Given this list of marker genes CARD10, FADD, FASLG, FAS, CBLB, PSMB9, CASP10, here is a description of the gene set: Any deviation from the normal range of the concentration of interleukin 10 in the blood circulation. Human Gene Set: HP_ABNORMAL_CIRCULATING_INTERLEUKIN_10_CONCENTRATION studied in species Homo sapiens Abnormal circulating interleukin 10 concentration